Given this list of marker genes Alg13, Ddit4, Depdc5, Otud7b, Prkacb, Klhl22, Syk, Akt1s1, Gna12, Rragc, Mtm1, Rheb, Prkaa2, Araf, Tbc1d7, Cryba1, Lep, Itfg2, Rnf152, Wdr24, Ep300, Akt3, F7, Htr6, Ywhaz, Kdr, Bmt2, Ube2n, Castor2, Slc7a1, Pdcd6, Fnip1, Pten, Csnk1a1, Slc7a3, Deptor (NCBI Gene Id 97998), Mat2a, Prex2, Wdr59, Gpr155, Sh3bp4, Sec13, Sar1a, Hif1a, Cul3, Atm, Wac, Stambpl1, C9orf72, Ube3a, Ros1, Srms, Gpat3, Lars1, Ube2d1, Rragb, Spaar, Gas6, Fam83d, Mapk3, Nckap1l, Mios, Kics2, Rragd, Szt2, Peli1, Xbp1, Lamtor2, Bmal1, Ccl5, Vhl, Gsk3a, Otub1, Stk11, Flcn, Castor1, Nprl2 (NPR2 like, GATOR1 complex subunit), Fnip2, Lin28a, Endog, Tsc2, Gpr137b, Prkaa1, Lamtor3, Npc1, Ubr1, Tnfaip8l1, Sik3, Sesn2, Reln, Lamtor5, Tti1, Usp9x (NCBI Gene Id 77016, ubiquitin specific peptidase 9, X chromosome), Fbxo9, Ube2w (NCBI Gene Id 66799), Ctns, Gsk3b, Nlk, Slc38a9, Sesn1, Zmpste24, Gpr137, Rptor, Ywhag, Usp7, Rps6ka1, F10, Gba1, Epm2a, Sar1b, Tsc1, Lamtor1, Rps6kb1, Lamtor4, Minar1 (membrane integral NOTCH2 associated receptor 1), Nprl3, Mlst8, Golph3, Pim1, Armh4, Foxp1, Sirt1, Rictor, Atxn3, Rraga, Gpr137c, Prex1, Prmt1, Akt1, Otud5, Prkaca, Mapkapk5, Usp4, Rbx1, Rbx1-ps, Sesn3, Ogt, Src, Pih1d1, Clec16a, Trem2, Tbk1, Smcr8, Tbck, Pkhd1, Ubr2, Dyrk3, Seh1l, Shq1, Usp32, Pip4p1, Rnf167, F3, Hdac3, Dgkq (NCBI Gene Id 13141), Tmem127, Kptn, here is a description of the gene set: Any process that modulates the frequency, rate or extent of TOR signaling. Mouse Gene Set: GOBP_REGULATION_OF_TOR_SIGNALING species: Mus musculus